The following is a description of a gene set: Absent outer dynein arms Absence of the outer dynein arms of respiratory motile cilia, which normally are situated outside of the peripheral microtubules of motile cilia. This feature is usually appreciated by electron microscopy. Human Gene Set: HP_ABSENT_OUTER_DYNEIN_ARMS studied in species Homo sapiens, and this is the list of marker genes: DNAAF3, DNAH9, DNAI1, DNAAF11, ODAD3, DNAL1, TTC12, DNAAF1, CFAP298, CFAP300, DNAI2, ZMYND10, ODAD1, DNAAF5